Given this list of marker genes TBX20, PAX6, SUFU, LBX1, DMRT3, CLN8, IFT172, ABT1, DAB1, ZC4H2, PTCH1, LHX4, DBX1, VLDLR, PHOX2A, MDGA2, DLL4, LONRF2, RELN, LMO4, FOXN4, SCYL3, ISL1, HOXC10, GBX1, VSTM5, GLI3, LHX1, SCYL1 (SCY1 like pseudokinase 1), NFE2L1, OLIG3, NKX2-2, GATA2, SOX1, TCTN1, ASCL1, GLI2, MNX1, DCTN1, OLIG2, DYNC2H1, SHH, GIGYF2, LRP8, ISL2, HOXD10, LHX3 (NCBI Gene Id 8022), here is a description of the gene set: species: Homo sapiens Human Gene Set: GOBP_VENTRAL_SPINAL_CORD_DEVELOPMENT The process whose specific outcome is the progression of the ventral region of the spinal cord over time, from its formation to the mature structure. The neurons of the ventral region of the mature spinal cord participate in motor output.